Given this list of marker genes Epb41l5 (NCBI Gene Id 98492), Cadm1, Cfl1, Edn2, Bin3, here is a description of the gene set: The process in which a cell irreversibly increases in size in one dimension or along one axis, resulting in the morphogenesis of the cell. Mouse Gene Set: GOBP_UNIDIMENSIONAL_CELL_GROWTH species: Mus musculus